Given this list of marker genes PHB1, CFHR2, CFH, ITGB2, CR1, CFHR4, CFHR5, CFHR1, VSIG4, CFHR3, ITGAM, here is a description of the gene set: studied in species Homo sapiens Binding to a C3b product of the complement cascade. Human Gene Set: GOMF_COMPLEMENT_COMPONENT_C3B_BINDING